Given this list of marker genes NEU1, ALG11, MOGS, GLB1, ALG12, MPDU1, CTSA, MAN1B1, ALG3, DPAGT1, MGAT2, B4GALT1, ALG13, ALG6, ALG9, RFT1, ALG1, ALG8, ALG14, ALG2, here is a description of the gene set: Reactome Pathway: Diseases associated with N-glycosylation of proteins part of: Diseases of glycosylation species: Homo sapiens Congenital disorders of glycosylation (CDGs) are a group of autosomal recessive disorders caused by enzymatic defects in the synthesis and processing of asparagine (N)-linked glycans or oligosaccharides on glycoproteins. These glycoconjugates play critical roles in processes such as metabolism, cell recognition and adhesion, cell migration, protease resistance, host defense, and antigenicity. CDGs are divided into 2 main groups: type I CDGs comprise defects in the assembly of the dolichol lipid-linked oligosaccharide (LLO) chain and its transfer to the nascent protein, whereas type II CDGs comprise defects in the trimming and processing of protein-bound glycans (Marquardt & Denecke 2003, Grunewald et al. 2002, Hennet 2012, Cylwik et al. 2013).